The following is a description of a gene set: Any process that results in a change in state or activity of a cell (in terms of movement, secretion, enzyme production, gene expression, etc.) as a result of an ATP (adenosine 5'-triphosphate) stimulus. species: Mus musculus Mouse Gene Set: GOBP_CELLULAR_RESPONSE_TO_ATP, and this is the list of marker genes: P2rx4, Ryr3 (ryanodine receptor 3), Trpv1, Abcc9, Ccl2, P2ry12, Trpm4, Ryr1 (NCBI Gene Id 20190), P2rx3, Pdxp, Top2b, Cib2, Ssh1, Ptgs2, Hsp90b1